The following is a description of a gene set: species: Homo sapiens Human Gene Set: GOBP_ESTABLISHMENT_OF_PIGMENT_GRANULE_LOCALIZATION The directed movement of a pigment granule to a specific location., and this is the list of marker genes: RAB17, ARL6, BLOC1S5, BBS2, DCTN1, MAP2K1, RAB11B, MYO5A, DCTN2, BBS5, MLPH, MYO7A, ASIP, MREG, RAB11A, BLOC1S3, BLOC1S6, BBS7, RAB27A, SHROOM2, GPR143, RAB1A, CDH3, MKKS